Given this list of marker genes IRF1, LAG3, MIR30B, TNFSF4, MDK, MIR21, CTLA4, here is a description of the gene set: species: Homo sapiens Human Gene Set: GOBP_NEGATIVE_REGULATION_OF_REGULATORY_T_CELL_DIFFERENTIATION Any process that stops, prevents, or reduces the rate of differentiation of regulatory T cells.